The following is a description of a gene set: Genes up-regulated in 786-0 cells (renal carcinoma, RCC) upon expression of VHL off a retroviral vector under normoxia (normal oxygen) condition. species: Homo sapiens The von Hippel-Lindau tumor suppressor, pVHL, is a key player in one of the best characterized hypoxia signaling pathways, the VHL-hypoxia-inducible factor (VHL-HIF) pathway. To better understand the role of VHL in the hypoxia signaling pathways of tumor cells, we used serial analysis of gene expression (SAGE) to investigate hypoxia-regulated gene expression in renal carcinoma cells (786-0), with and without VHL. The gene expression profiles of the cancer cells were compared to SAGE profiles from normal renal proximal tubule cells grown under both normoxia and hypoxia. The data suggest that the role of VHL as a tumor suppressor may be more complex than previously thought. Further, the data reveal that renal carcinoma cells have evolved an alternative hypoxia signaling pathway(s) compared with normal renal cells. These alternative hypoxia pathways demonstrate VHL-dependent and VHL-independent regulation. The genes involved in such pathways include those with potential importance in the physiological and pathological regulation of tumor growth and angiogenesis. Some of the genes identified as showing overexpression in the cancer cells, particularly those encoding secreted or membrane-bound proteins, could be potential biomarkers for tumors or targets for rational therapeutics that are dependent on VHL status. Human Gene Set: JIANG_VHL_TARGETS from publication Jiang Y, Zhang W, Kondo K, Klco JM, St  Martin TB, Dufault MR, Madden SL, Kaelin WG Jr, Nacht M (PMID 12692265), and this is the list of marker genes: MPHOSPH6, COTL1, BCL7B, RPL26L1, UACA (NCBI Gene Id 55075), PITRM1, SLC3A2, RAB14, SPATS2L, EWSR1, RPS6KA1, TBC1D13, PEA15, SIRT6, ABCB8, PNKD, SLC39A13, ELANE (elastase, neutrophil expressed), ACOT13, PECR, TROAP, KGD4, BRIX1, TNFSF10, PDGFRA, PRKCH, LSM3, PPP2R5D, PAQR3, MYG1, LRP1, SGSM3, GMFB, NFE2L1, PCNA, C1D, CFAP298, HILPDA, MRPL15, MKI67, IKBKE, OXA1L, AZIN1, SLC7A5, INF2, PATZ1, RAB11A, FAM53C, VIRMA (NCBI Gene Id 25962), ARTN, MTHFD1, LAMP1, CSE1L, PAQR4, POLD1, TNNC2, GFUS, TES, HDAC6, IFT25, SPG21, AIMP1, CAPN1, ZNF395, EIF3G, DGCR6L, TRIP10, STK24, CANX, IRF1, SCARB2 (NCBI Gene Id 950), CDK2, MRPS6, RANBP9, MT1L, REX1BD, TRAPPC2L, TMEM222, ENO2, PES1, TMEM50A, NIPSNAP1, C1orf159, RNF130, FBH1, RPLP0, VAPB, TCEAL9